The following is a description of a gene set: studied in species Homo sapiens Genes having at least one occurrence of the highly conserved motif M65 ARGGGTTAA in the regions spanning 4 kb centered on their transcription starting sites. The motif does not match any known transcription factor binding site. Comprehensive identification of all functional elements encoded in the human genome is a fundamental need in biomedical research. Here, we present a comparative analysis of the human, mouse, rat and dog genomes to create a systematic catalogue of common regulatory motifs in promoters and 3' untranslated regions (3' UTRs). The promoter analysis yields 174 candidate motifs, including most previously known transcription-factor binding sites and 105 new motifs. The 3'-UTR analysis yields 106 motifs likely to be involved in post-transcriptional regulation. Nearly one-half are associated with microRNAs (miRNAs), leading to the discovery of many new miRNA genes and their likely target genes. Our results suggest that previous estimates of the number of human miRNA genes were low, and that miRNAs regulate at least 20% of human genes. The overall results provide a systematic view of gene regulation in the human, which will be refined as additional mammalian genomes become available. from publication Xie X, Lu J, Kulbokas EJ, Golub TR, Mootha V, Lindblad-Toh K, Lander ES, Kellis M (PMID 15735639) Human Gene Set: ARGGGTTAA_UNKNOWN, and this is the list of marker genes: CORO2B, MIP, TGFB1I1, KCNJ8, SPTBN4, TCF7L2 (transcription factor 7 like 2), CELSR3 (NCBI Gene Id 1951), DCDC1, DMPK, PAMR1, CCDC120, SLC16A6, DUSP10, B3GNT7, BLVRB, INSRR, NAA80, TUBA4B, SMAD6, EPN3, PLEKHG6, HIVEP1 (NCBI Gene Id 3096), ZNRF1, CD86, SPDEF, DHRS3, MAF, IL11, BMP5, PDGFB, CSMD3, ACTR1A, TRPS1, ELOVL6, ATXN1, HADHA, WFIKKN2, CRABP2, KLK6, ZNF532, CREB1, NTN5, TUBA4A, GPR20, WDR82, SUFU, TNS1, FGF9, CDH5, RARG, VCAM1, PLEC, NUMB, PEX13, FLI1, HTN1, POFUT1, PLAGL2, ITPKC, NECTIN1, ARHGAP18, MRPS18B (mitochondrial ribosomal protein S18B), HES1, RHEBL1, CCDC80, LHFPL1, EXTL1, YWHAZ, RGS6, RTKN, GLI1, CDKN2C, PUS10, ABI2, NECTIN2, SYT4, NEUROD1, FLNC, COQ8B, BMI1, KCNF1, NHSL2, ATP1B1, HAS2, FGF16, CYP26B1, NES (nestin), AXL, HOXB6, ESR1, CDK2AP1, GAS7, PKP3, S1PR1, LINC02875, ISL1, MYL6B, PLEKHH3, SLC24A4, RPH3A, NLGN3, H2AX, ZFHX3, NCDN, LAMA5, SREBF2, CRMP1, KLK13, SAMD3, KLF12, DSTN, RUNX1T1, GRIK3, TLK2, PPP1R10, ZNF827, TMEM125, HADHB, BRSK1, HYAL3, HAND1, TP63, SFRP1